Given this list of marker genes TMEM223, MT-CO1, HIGD2A, COX18, COX5A, SCO1, PNKD, COX19, COX14, TACO1, COX15, COX8A, COX11, COX7C, SMIM20, HIGD1A, COX5B, COQ10A, COX7A2L (NCBI Gene Id 9167), COXFA4, SCO2, MT-CO2, COX6B2, COX4I1, COX7A2, COX8C, COX20, COX16, COX7B, COX6B1, COA3, COX6A2, COA1, TIMM21, PET100, MT-CO3, COA5, COX6C, COX17, CMC1, COX4I2, TMEM177, COX6A1 (NCBI Gene Id 1337), PET117, RAB5IF, SURF1, COX7A1, COQ10B, here is a description of the gene set: part of: Respiratory electron transport At least 30 proteins are required to form the functional human complex IV, 14 of which are complex subunits. The complex contains the cofactors heme a, heme a3, and one mononuclear copper (CuB) center in the COX1 subunit, and a binuclear copper (CuA) in COX2, as well as several lipid molecules (phosphatidylethanolamine, PE, cardiolipin, CL) in different subunits (PDB 5Z62; Zong et al., 2018). The insertion of these cofactors is an intricate process requiring many assembly factors.<br><br>Mutations in any complex IV subunits or assembly factors lead to different types of complex IV deficiency, usually manifesting as Leigh syndrome (MIM:220110; reviewed in Pecina et al., 2004; Čunátová et al., 2020) Reactome Pathway: Complex IV assembly studied in species Homo sapiens